Given this list of marker genes Six3, Hipk2, Bmp4, Pou2f1, Tfap2a, Sox2, Hipk1, here is a description of the gene set: Mouse Gene Set: GOBP_LENS_INDUCTION_IN_CAMERA_TYPE_EYE species: Mus musculus Signaling at short range between the head ectoderm and the optic vesicle that results in the head ectoderm forming a lens.